The following is a description of a gene set: species: Homo sapiens Abnormality of facial adipose tissue Human Gene Set: HP_ABNORMALITY_OF_FACIAL_ADIPOSE_TISSUE, and this is the list of marker genes: ERCC6, CIDEC, POLR3A, ZMPSTE24, PSMB8, PPARG (NCBI Gene Id 5468), LMNB2 (NCBI Gene Id 84823), ERCC8, KCNJ6, LMNA